Given this list of marker genes WT1 (WT1 transcription factor), NR2F2, GATA6, NDUFAF5, ALDH1A2, here is a description of the gene set: studied in species Homo sapiens Human Gene Set: HP_APLASIA_OF_THE_LEFT_HEMIDIAPHRAGM Aplasia of the left hemidiaphragm Congenital absence of the left half of the diaphragm.